Given this list of marker genes MIR361, GGA3, MIR29C, RTN3, MIR24-1, BIN1, RTN4 (NCBI Gene Id 57142), CLU, MIR15B, SPON1, MIR455, MIR29B1 (NCBI Gene Id 407024), ABCA7, NTRK2, MIR103A1, RTN1, RTN2, FLOT2 (NCBI Gene Id 2319), MIR16-1, ROCK1, APOE, IGF1, MIR153-1, SORL1, CHRNA7, MIR339, PRNP, MIR298, MIR15A, PIN1, HAP1, MIR186, MIR107, MIR29A, here is a description of the gene set: Human Gene Set: GOBP_NEGATIVE_REGULATION_OF_AMYLOID_PRECURSOR_PROTEIN_CATABOLIC_PROCESS species: Homo sapiens Any process that stops, prevents or reduces the frequency, rate or extent of amyloid precursor protein catabolic process.